Given this list of marker genes CTNNB1, MAD1L1, EP300, KEAP1, CREBBP, DICER1, APC, KMT2D, KDM6A, here is a description of the gene set: Pilomatrixoma studied in species Homo sapiens Pilomatricoma is an asymptomatic slowly growing benign cutaneous tumor, differentiating towards the hair matrix of the hair follicle. It is covered by normal or hyperemic skin, and usually varies in size from 0.5 to 3 cm. Human Gene Set: HP_PILOMATRIXOMA